Given this list of marker genes Emb (NCBI Gene Id 218679), Fos, Il7r, Zfp36l2, Rgs1, here is a description of the gene set: from publication Cui A, Huang T, Li S, Ma A, Pérez JL, Sander C, Keskin DB, Wu CJ, Fraenkel E, Hacohen N (PMID 38057668) Mouse Gene Set: CUI_NK_CELL_IL27_RESPONSE_DN Cytokines mediate cell-cell communication in the immune system and represent important therapeutic targets. A myriad of studies have highlighted their central role in immune function, yet we lack a global view of the cellular responses of each immune cell type to each cytokine. To address this gap, the authors created the Immune Dictionary, a compendium of single-cell transcriptomic profiles of more than 17 immune cell types in response to each of 86 cytokines (>1,400 cytokine-cell type combinations) in mouse lymph nodes in vivo. A cytokine-centric view of the dictionary revealed that most cytokines induce highly cell-type-specific responses. For example, the inflammatory cytokine interleukin-1β induces distinct gene programmes in almost every cell type. A cell-type-centric view of the dictionary identified more than 66 cytokine-driven cellular polarization states across immune cell types, including previously uncharacterized states such as an interleukin-18-induced polyfunctional natural killer cell state. Genes negatively differentially expressed in cell type: NK cell upon treatment with cytokine: IL-27 in mouse lymph nodes in vivo. species: Mus musculus